The following is a description of a gene set: studied in species Homo sapiens from publication Ng SY, Yoshida T, Zhang J, Georgopoulos K (PMID 19345118) Regulation of lineage potential and transcriptional priming by Ikaros. New insight is provided into a bivalent regulation of lineage priming in the HSC and its lympho-myeloid restricted progeny the LMPP by the lymphoid lineage-determining factor Ikaros Whereas Ikaros is responsible for the activation of a cascade of lymphoid expression programs and for the establishment of lymphoid potential from the HSC to the LMPP it is also responsible for the repression of stem cell and erythroid genetic programs that are incompatible with further lineage restrictions emanating from the LMPP Human Gene Set: GSE15330_WT_VS_IKAROS_KO_GRANULOCYTE_MONOCYTE_PROGENITOR_DN Genes down-regulated in granulo-monocyte progenitors: wildtype versus IKZF1 knockout., and this is the list of marker genes: GJA8, SYNE1, BMPR1A, SKIL, SOCS3, CSNK2A2, CYP2S1, CRIP1, NUCB2, TXK, NECAP2, MARCHF2, SLC9A1, ELOC, LAMC2, ZDHHC12, PRNP, SSR3, DDR2, RPRD1B, COMMD5, ACSBG1, PGS1, PIWIL2, TRAK1, ZFP36L2, NRSN1, LPP, RBMS1, GDI1, CRK, KCNE2, PRR13, MKNK2, TANC1, VPS39, EPN1, MPHOSPH6, PLAGL2, IL12RB2, RNF149, FLOT1, PSAP, SLC43A3, TEX264, ZNF565, TMX1, SPATS2, NFIL3, IGF2R, RNH1, INPP5A, FBXW11, RUNX2, ABCG1, PLOD3, RAPGEF3, MARCKS, ATP8A2, ACOT7, CYTH1, ATOSB, STAT5B, MSRB1, UPP1, SLC17A2, HIP1, INO80C, TMIGD1, CD2, GSN, AFF1, TPBG (trophoblast glycoprotein), ZC3H10, CXCR5, RRAD, CTNNA1, RALBP1, JUN, ADA, NLGN2, PPT2, RASSF7, ATP10A, KDELR1, CYP11A1, PLP2, GATAD2A, GJA1, YWHAH, VCL, TAX1BP3, EPB41L2, MNT, SH3BGRL3, GM2A, PLOD2, EDIL3, LRPAP1, PPP3CC, SDCBP2, TAB2, TRIM13, NUBP2, PMFBP1, NRCAM, APLP2, SLC35F6, ARHGDIG (Rho GDP dissociation inhibitor gamma), CDC42SE1, COPG1, ATP12A, CELA1, B4GALT1 (NCBI Gene Id 2683), CRLF1, CKS2, TYRP1, SUN1, CWH43, FBXL3, IL2RB, CDKN1B, ANXA3, KCNAB2 (NCBI Gene Id 8514), FOXF2, TSPAN6, RAB29, STMN1, MYO5A, PHETA2, TXNDC17, SLC25A30, RIC8A, CACNB4, CALHM2, ANGPTL2, VSTM2A, ITGA3, AAMDC, KLF13, EDEM2, NCOA3, ARRB2, CST3, ILDR1, SERPINE1, CTLA4, SGK1, HEMK1, THPO, RALA, NEAT1, PABIR1, S100A13 (NCBI Gene Id 6284), THAP11, MYBL1, MAPK14, AVIL, ANXA5, PLEKHF2, PAK1, LRBA, SNAP29, GPR65, DIPK2A, KIFAP3, CLIC1, ANKH, SEC24D, MITF, LPXN, C2CD2L, CTSW, BMP2K, HCLS1, ADAM9, NEK6 (NIMA related kinase 6), GLRA1, GBA1, ITPR3, IFT22, ITPK1, NECTIN3, GPR83 (G protein-coupled receptor 83), PAFAH1B1, RACGAP1, REEP1, ADAM8, PXN (NCBI Gene Id 80229), BIRC3, EMP3, VPS29 (VPS29 retromer complex component), SS18, CDC6, LPP-AS2, FOXM1, DYNLT5, MYOF, SCN3B, KLF6